The following is a description of a gene set: studied in species Mus musculus Any process that activates or increases the frequency, rate or extent of a process involved in the formation, arrangement of constituent parts, or disassembly of a vacuole. Mouse Gene Set: GOBP_POSITIVE_REGULATION_OF_VACUOLE_ORGANIZATION, and this is the list of marker genes: Rab3gap2, Ulk1, Pip4k2b, Rab3gap1, Elapor1, Anxa2, Grn, Wdr45, Atg2a, Snx4, Snx7, Pip4k2a, Igtp, Moap1, Lrsam1, Snx30, Snx18, Sh3glb1, Pip4k2c, Ppp3cb, Ralb, Irgm1, Trim32, Becn1, Irgm2, Mcoln1, Wipi1